The following is a description of a gene set: Binding to a ubiquitin-like protein conjugating enzyme such as ubiquitin conjugating enzyme. Mouse Gene Set: GOMF_UBIQUITIN_LIKE_PROTEIN_CONJUGATING_ENZYME_BINDING species: Mus musculus, and this is the list of marker genes: Rnf217, Rnf180, Trim72, Uba2, Siah3, Dcun1d3, Ube3d, Rnf40, Rnf14, Arih1, Tes3-ps, Rnf144b, Park7, Dcun1d1, Dcun1d4, Dcun1d5, Rnf144a, Zmym2, Rps3, Aup1, Rnf4, Rnf19a, Rasd2, Arih2, Rnf19b, Rnf5, Ankib1 (ankyrin repeat and IBR domain containing 1), Tcerg1, Tollip, Marchf7, Siah1b, Siah2, Grik2, Marchf6, Ppara, Traf6, Dcun1d2, Rnf185, Rnf125, Foxl2, Ube2v1, Siah1a, Prkn